Given this list of marker genes TEK, C1QTNF5, LRP5, ZEB2, ASPH, LTBP2, ROBO1, MYOC, COQ2, CYP1B1, VWA8, OVOL2, here is a description of the gene set: Iris atrophy Human Gene Set: HP_IRIS_ATROPHY Loss of iris tissue (atrophy) studied in species Homo sapiens